Given this list of marker genes Hdac2, Mef2c, Ezh2, Mir208b, Hdac8, here is a description of the gene set: species: Mus musculus Any process that results in a change in state or activity of a cell (in terms of movement, secretion, enzyme production, gene expression, etc.) as a result of a trichostatin A stimulus. Mouse Gene Set: GOBP_CELLULAR_RESPONSE_TO_TRICHOSTATIN_A